The following is a description of a gene set: Any process that modulates the frequency, rate or extent of endothelial cell development. species: Mus musculus Mouse Gene Set: GOBP_REGULATION_OF_ENDOTHELIAL_CELL_DEVELOPMENT, and this is the list of marker genes: Proc, Tnfrsf1a, Akap11, Plcb1, Add1, Vegfa, Dicer1, Vcl, Rock2, Rock1, F11r, Il1b, Cldn5, Tnf, Ikbkb, S1pr3, S1pr2, Cdh5, Zdhhc21